Given this list of marker genes Ubb, Engase, Derl1, Amfr, Psmc1, Rps27a, Calr, Vcp, here is a description of the gene set: part of: Asparagine N-linked glycosylation studied in species Mus musculus This event has been computationally inferred from an event that has been demonstrated in another species.<p>The inference is based on the homology mapping from PANTHER. Briefly, reactions for which all involved PhysicalEntities (in input, output and catalyst) have a mapped orthologue/paralogue (for complexes at least 75% of components must have a mapping) are inferred to the other species. electronically inferred by orthology from the curated human pathway Reactome Pathway: N-glycan trimming in the ER and Calnexin/Calreticulin cycle